Given this list of marker genes DDX18, PDIA6, MET, MRPL15, COMMD5, TRAPPC4, KRT10, RABEPK, NUP133, UFD1, IKBIP, MGAT2, DAAM1, MT1X, IPO5, SEC23IP, ZWINT, ICE1, ERAP1, RINT1, DNAJB4, SAMD9, TTI1, HSPA5, GBP1, CLSPN, BAG5 (BAG cochaperone 5), ZNF506, FRMD8 (FERM domain containing 8), PPIB, CDC25A, SRSF8, RBM3, NXF1, IPO11, TBC1D9, FASTKD2, IKZF1, BCCIP, DNAJB11, CCDC85A, HCCS, MAGT1, RRP1B, PSMB5, ZNF451, PSMC5, SRSF11, NOLC1, EMG1, ASCC3, RRM2, RAN, CHORDC1, MRPL1, HNRNPC, FAR1, BLNK, RRP15, SERTAD2, MED7, STX7, THADA, ELOA, UBAP2L, NOP2, GPR183, SGMS1, PSMA7, EIF2S1, CCT6A (chaperonin containing TCP1 subunit 6A), BRI3BP, POLA2, MAP3K7, WWP1 (NCBI Gene Id 81891), KDSR, DLEU1, PMPCA, ISCA1, KBTBD6, ACKR4, IFIT1, DHX29, RAB29, UCHL5, GPATCH4 (G-patch domain containing 4 (gene/pseudogene)), HNRNPM, DNAJA1, MS4A1, RBM4, TRMT10C, GLMN, SRSF3, ADSL, RDH13, SLC35B3, TRMT10A, TLR10, XPO4, MANEA (NCBI Gene Id 79694), POLR1F, PPIG, PPIL1, CSTF2T, TMEM33, PUM3, BASP1, SLC11A2, SNHG4 (NCBI Gene Id 724102), CD86, CDK2AP1, NME1, GDAP1, EIF4E2 (eukaryotic translation initiation factor 4E family member 2), ZBTB24, UFM1, FARSA, AIM2, RSC1A1 (NCBI Gene Id 6248), CNOT7, FPGT, PSMD13, WDR36 (NCBI Gene Id 574015), FBXO5, PSMC6, UBE2L3, API5, CFL2, ATP6V0E1, QRSL1 (NCBI Gene Id 80136), CYB5B, EIF5, PRELID1, BAG2, SNRPC, RRP9, UGDH, OGA (O-GlcNAcase), SRSF10, TXNDC9, RARS1, DDX20, TWNK, GNL3L, METTL13, RFC3, NHLRC2, SDF2L1, ETS1, APTX, ZNF407, PPWD1, QTRT2, BZW1, SAMM50, CSTF2, DNTTIP2, SRSF1, AFF3, PGM2, PHAX, ADI1, ATP6V1C1, SIGLEC10, SYNCRIP, KLC1, TANK, EBNA1BP2, SEPHS1, RCL1, MRPS16, CYBB, FAM98A, CUL4A, PGRMC2, NLN, SGK3, FCGR2B, CREM, PLAA, CASP1, HSP90B1, TIA1, LTB, TSFM, CNPY2, FUBP3, AMD1, KMO, USP16, MAGOHB, PIGW, SOAT1, YTHDF3, UBE2K, HSPA1A (NCBI Gene Id 3303), MRPL20, GMFB, NASP, SAP18, KPNB1, CDC27, CNDP2, MSANTD7, GAR1, NCBP1, CEBPZ, FLAD1, RUNX1T1, GTF2H2 (NCBI Gene Id 2966), MRPS23, DTL, CNOT4, MAX, RPF1, POLE2, RPP40, WBP4, SNHG14, SERBP1, RHOH, NAV2, PALLD, MRPL30, RBM25, HEATR1, TDG, ASNSD1 (NCBI Gene Id 54529), NOP56, YRDC, MRPS12, KIF14, AIMP2, BMP2K, MRPL32, WDR77, MTMR4, HSPA1B, ZNF367 (zinc finger protein 367, NCBI Gene Id 195828), COX5A, BCL11A, LCMT2, LARP4, UMPS, AP4S1, CHUK, TXNIP, TUBA4A, GSPT2, PSMF1, DYRK2, DANCR, FOXO1, TAF9B, ZCCHC10, ILF3 (interleukin enhancer binding factor 3), NDUFB7, RNF138, TIPIN, DTYMK, IKZF5, POLR3G, CENPI, CCNB1, BLZF1, PNRC2, CHCHD7, BIRC5, DRG1, LSM10, GRSF1, STAG1, PAPOLA, GEMIN6, MESD, H3-3B, ZNF207, SSU72, ATP2B1, SKP2 (NCBI Gene Id 86997), EIF3JP1, SNRPD3, SLC30A7, WDR3, FEN1, MRPS11, DLEU2, SOD2, KBTBD8, ANP32A, SLC44A1, DDX27, UBE2F, DDX46, METAP2, PLEKHF2, DCTPP1, GTPBP4, RBM8A, ANAPC7, LANCL2, FBXO28, PAFAH1B1, PSMC3, GNL2, TNPO1, SLC30A5, UHRF1, FUBP1, USP15, DHX9, USP6NL, SRI, PNO1 (partner of NOB1 homolog), MRPL35, CCNE2 (cyclin E2), OIP5, SLC25A19, PDP2, EIF2B1, CHST11, OTUD6B, KIF23, PNP, CCAR1, ARL5B, HLA-DMA, SERPINA9, MSANTD4, MANF, KLF10, INTS2, KPNA2, GFM1, AZIN1, CENPF, PNN, DDX1, LARS2, IDE, ABT1, CDK12, AK4, SENP6, RFC2, CEP152, GEMIN4, STIP1, FIGNL1, AP4B1, BTN3A3, TM2D2, SRRT, MRPS17 (NCBI Gene Id 64958), DNAJB6, PAK1IP1, ALG13, ZNG1A, PBRM1, RNF20, TSN, UTP15, RLIM, TNPO2 (transportin 2), PQBP1, TRMT5, ZDHHC16, GMNN, RBMX, FMR1, CUL2, EIF3J, GALNT7, SRFBP1, PSMC2, PHB1, ELP1, HSPH1, HSPA4 (NCBI Gene Id 3308), ENSA (NCBI Gene Id 51620), HINT1, GANAB, ABCF2, SRSF2, ERCC6L, BCLAF1, MRPL50, DNAJC10, DNAJC9, GINS1, RANBP6, RALGPS2, SP140, MYBL1, PDCD5, RBM22, HLA-DPA1, TFRC, KIAA1586, MRPL36, RBM14, ETF1, CRYZ, PPP4R3B, POLE3, TNFAIP8, TFAM, SH3TC1, SELENOK, IRF8, EIF1AX, ATR, CITED2, EMB, UTP3, NOL11, TLR1, GTF2H1, DNAJC7, PFDN1, NUDC, STK17A, SBDS, HNRNPD, POLR1C, DYNC1LI1, CDK5RAP1, SERF2, TWF1, NOP58, TPR, GAS5, OAS1, EIF2B4, PRPF38B, TARDBP, NUP160, IFI35, PAN2, PSMD1, here is a description of the gene set: studied in species Homo sapiens from publication Gary-Gouy H, Sainz-Perez A, Marteau JB, Marfaing-Koka A, Delic J, Merle-Beral H, Galanaud P, Dalloul A (PMID 17878328) Chronic lymphocytic leukemia (CLL) results in the accumulation of B cells, presumably reflecting the selection of malignant cell precursors with Ag combined with complex alterations in protein activity. Repeated BCR stimulation of normal B cells leads to anergy and CD5 expression, both of which are features of CLL. Because CD5 is phosphorylated on tyrosine following BCR engagement and negatively regulates BCR signaling in normal B cells, we investigated its phosphorylation status and found it to be naturally phosphorylated on tyrosine but not on serine residues in CLL samples. To analyze the role of CD5, we established a B cell line in which CD5 is phosphorylated. Gene profiling of vector vs CD5-transfected B cells pointed out gene groups whose expression was enhanced: Apoptosis inhibitors (BCL2), NF-kappaB (RELB, BCL3), Wnt, TGFbeta, VEGF, MAPKs, Stats, cytokines, chemokines (IL-10, IL-10R, IL-2R, CCL-3, CCL-4, and CCR7), TLR-9, and the surface Ags CD52, CD54, CD70, and CD72. Most of these gene groups are strongly expressed in CLL B cells as compared with normal B cells. Unexpectedly, metabolic pathways, namely cholesterol synthesis and adipogenesis, are also enhanced by CD5. Conversely, CD5 inhibited genes involved in RNA splicing and processing, ribosome biogenesis, proteasome, and CD80 and CD86 Ags, whose expression is low in CLL. Comparison of CD5- vs tailless CD5-transfected cells further demonstrated the role of CD5 phosphorylation in the regulation of selected genes. These results support a model where CLL cells are chronically stimulated, leading to CD5 activation and cell survival. In addition to CD5 itself, we point to several CD5-induced genes as potential therapeutic targets. Genes down-regulated in Daudi cells (B lymphocytes) stably expressing CD5 off a plasmid vector. Human Gene Set: GARY_CD5_TARGETS_DN